Given this list of marker genes PRR4, BCL2, DGKA, CKMT2-AS1, MT1E, SFRP1, CCL20, LINC01133, GNE, BICDL2, TNFAIP8, PTGER4, NCALD, GPR173, CYP4X1, KCNK6, SAYSD1, MGAT2 (alpha-1,6-mannosyl-glycoprotein 2-beta-N-acetylglucosaminyltransferase), FAN1, CBLC, BCL3, SPATA13, ATL3, ZNF554, MESP1, TSPAN1, CLDN10, ABO, CYP4V2, MUC20, SHLD2, COL28A1, SRGAP1, CRYM, NEBL, NTN1, CXCL6, CBR3, SMIM22, ZNF774, ZC3H3, SLC49A3, VTCN1, CBFB, ACSL4 (acyl-CoA synthetase long chain family member 4), SLCO3A1, SLC35F6, NMRK1, CASP4, CRYBB2, SH2D3A, TYMP, TNFSF13B, NRAD1, PKN2-AS1, GAL3ST4, CCDC146, IGFBP3, MYO18A, PFKP, TNFRSF14, FOXRED2, MIR200CHG, MIRLET7BHG, TMEM63A, KCNN4 (potassium calcium-activated channel subfamily N member 4), PRSS21, ELAPOR1, B3GNT5, TRIM47, SOX21, ZNF217, TTYH1, CCDC160, ANKRD9, OAF, ARHGAP27, ATP2A3, NPM2, TTC9, GDPD5, SHC2, NBPF3, C10orf143, MFSD6L, CAPN10, EZH1, GRHL1, LINC00920, SYT7, PHLDA2, CHFR, F8A1, CFH, MEIS1, TUBB6, STXBP5, CAVIN1, NALCN, PITPNM3, HLA-B, CBX4, RRAS, PIM2 (Pim-2 proto-oncogene, serine/threonine kinase), SEZ6L2, DST, EXTL3, SLC1A5, TGM5, TMEM40, KCNMA1, BTBD6, GABRP, PHF7 (NCBI Gene Id 51533), HTRA1, NEURL3, AK4, ZNF701 (zinc finger protein 701), CALML5, CFAP96, SH3PXD2B, SNX19, S100A2, SLC25A25-AS1, GCLM, AJM1, INHBB (inhibin subunit beta B), C8orf58, PRR15, PPP1R3F, TMT1A, EDEM1, CIMAP1B, CEACAM6, ARHGEF3, AEN, PSME4, SLC30A4, CAVIN3, PHLDB3, SOCS6, CHAF1B, SULT1A3, PTPN18, PCDHB16, NOL3, LHFPL2, RAPGEF5, CPEB2, RTTN, ATL1, SULF2, ZBTB7C, FAM83E (NCBI Gene Id 54854), PLLP, PPP5D1P, LZTS3, MARCHF3, SLC66A2, GALNT6, ARRDC4, EFHD1, SDCBP2-AS1, GRAMD2B, MIF4GD, FAM83A, IDH1-AS1, MICALL2, SPDEF, PYGL, TCN1, REPS2, TSPAN5, ITFG2-AS1, TENT5A, GHR, ANG, NPB, COMTD1, RASAL1, DHRS12, RGS10, NOP14-AS1, GLIS3 (NCBI Gene Id 648268), NPNT, BARX2, HS3ST1, TFAP2C, LNX1, ITGB8, IL17RC (interleukin 17 receptor C), C19orf73, LINC01473 (long intergenic non-protein coding RNA 1473), DTX4, AVPI1, C14orf93, MRAS, NECTIN1, CAPS, S100B, UBXN8, KANK4, PRKAR2B, CCT6B (chaperonin containing TCP1 subunit 6B), DNAJC28, LENG9, IQSEC2, TIRAP, FAM3D, METRN, C17orf58, CD40, CDR2, SRF, MMP7, NCK2, KLK10, PLAAT3, THBS3, SPHK1, HSH2D, A1BG, SQOR, TACC2, EMB, SELENOV, KAT2B, FAM229A, CHRM3, BIK, TEX261, STK10, SH3BP4, KRT6B, LYN, CNNM4, EIF4EBP3, RILPL2, ST6GALNAC1, CRLF3, ERCC6L2-AS1, C1orf115, JDP2, STEAP1, DEPTOR, SLC39A8, CLDND2, ALDH1A3, ERAP2, MICALL1, CATSPERG, CCSAP, KRT23, PODXL, PDZK1IP1, ANGPT2, LURAP1L, REEP2 (receptor accessory protein 2), CDKN1A, VEGFC, ASB13, RPS6KA4, GSTA1, TNFAIP2, RHBDL1, FNDC10, NPIPB11, BPGM, HARBI1 (harbinger transposase derived 1), ZNF788P, PALLD, TMEM71, SLPI, IQCH-AS1, CCL28, RNF144B, MCC (MCC regulator of WNT signaling pathway), PHLDA1, PER2 (NCBI Gene Id 8864), ADAD2, EYA2, WNT5B, SLC4A11, TFAP2A, C17orf49, KCTD14, ANO1, SZT2, ARID5A, GXYLT2, SECTM1, RRAGD, SLCO1A2, HAPLN3, FOXQ1, NMNAT3 (NCBI Gene Id 349565), TMEM241, PITPNC1, GALNT12, TNFSF10, C2CD4D, KRT14, FRMD6, CRIM1, RAB27B, KIF16B, CP, SLC22A23 (solute carrier family 22 member 23), NUPR1, TAPBPL, KLK11, SLITRK6, MARCHF2, SMPDL3A, PDE12, MGP, BAK1 (NCBI Gene Id 578), CLCF1, PLA2G6, MAP1B, IGFBP4, RIPOR2, RDH13, SLC5A1, RRP36, ANPEP, KHDRBS3, BCDIN3D, TPBG, CD14, A2M, BLM, VSIR, LGR4, ZNF449, PACS1, WFIKKN1, LRIG1, PPM1H, SELENOM, CDCP1, OPLAH (NCBI Gene Id 55579), HDHD5-AS1, FRZB, NPDC1, PNPLA7, CD3E, GMPR, SLC33A1, SGPP2, CFD, PINK1, GGT6, MZF1-AS1, DAGLB, TSHZ2, SYCE1L, GNG7, BCAR3, PXDC1, GLIPR2, CITED4, NEURL4, PALMD, F3, PRKCH, SYTL3, PPP1R1B, ADAM28, FOSL1, CRYAB (crystallin alpha B), TRIM17, MLYCD, ANKRD35, SLC37A1, NTRK2, CLPB, ABHD17B, RHOV, GATM, USP43, SLC44A4, PCSK6, PSMG3-AS1, PROM1, TOX3, MHENCR, ZNF212, NUMBL, CRACR2A, AQP5-AS1, ESYT2, ADM2, PITPNA, TNFSF12, BAIAP3, AZGP1, ACP5, TSPAN8, H2AC15, EHF, RBP7, MOB3C (NCBI Gene Id 148932), RORA, SCGB1A1, PPFIA3, MLPH, COL6A2, RCAN1, PPT2, PTPRE, TMC5, PPFIBP2, NQO1, GABBR1, CSTA (NCBI Gene Id 378889), FABP7, WHRN, KRT15, CNFN, INHBA, TENT5B, SLCO4C1, PEX11G, CYTH3, LTC4S, MIATNB, ABHD17C, TMEM139, RNF152, TMCO4, DENND5A, SPSB2, ZNF70 (zinc finger protein 70), DHRS4L2, ABCB10, ARHGDIB, CIMAP1C, SH3BP5, CCNO (NCBI Gene Id 9998), FBXO32, COG8, ABCA3 (NCBI Gene Id 21), HHAT, NPHP3, ADIPOR2, LTF, PIP, ARHGEF37, SLIT3, ADGRG1, ARHGAP31-AS1, PIK3CD-AS2 (NCBI Gene Id 101929074), FBXL8, PIK3IP1, RETSAT, MMAA, SOX21-AS1, IKBKE, ZDHHC2, ZFPM1, LINC00847, KLF11, RUNX1 (NCBI Gene Id 861), GNA15, HIVEP3 (HIVEP zinc finger 3), BBS5, CDC42EP2, TSLP, THSD4, PART1, ARSJ, ANXA1, MAFB, FMOD, BORCS6, B3GNT3, NPEPL1, RBM27, POU2F3, NACAD, ENDOG, MFSD6, FOLH1, APOBEC3C, AREL1, SH3RF1, DOCK9, ZNF296, NSMF, NBL1, LRRC26 (leucine rich repeat containing 26), ISL1, LINC00992, RNF150, LYPD3, ST3GAL4, PADI2, MEG3, PROSER2, PDK3, BMAL1, WNK2, STEAP2, WIPI1, IQCH, AQP5, FUT2, TRPS1, FGD5, SOX10 (NCBI Gene Id 8223), TIMP1, ORAI1, IFI16, RUNX3, PTH2R, TAP2, TGM2, CXCL3, RTN4IP1, ZSWIM8, SLC2A9, PKP2, EVA1C, HEY2, ZNF598, KAZALD1, STPG1, PDE4B, PTRH1, SFN, MYO15B, PMEPA1, CLYBL, ITGB4, CD82, GFM1, SMIM31, PLPP2, ZNF750, SLC25A10, SLC43A3, GLYATL2, GK, PLAAT4, PHF8, MKRN2OS, GRTP1, SERTAD4, NIPAL2, AGFG2, SLC5A8, ATG2A, ST20, RIC3, LINC01644, ST3GAL1, LINC01198 (NCBI Gene Id 101929344), LRATD1, ARHGEF11, DTX2, ELMO1, ABHD15, MUC5B, SLC25A42, SERTAD4-AS1, CNTN4, WAC-AS1, SUSD6, ANKRD13C-DT, KRT86, DUSP4 (dual specificity phosphatase 4), CRPPA, TCEA3, TM4SF1, IQGAP2, TIGD2, RASSF6 (Ras association domain family member 6), DCUN1D1, C9orf152, TNFSF13 (TNF superfamily member 13), RENBP, KLF9, VCAN, NOXO1, RASSF5, FBXO6, ZNF30, SLC15A2, EPS8L1, PAX9, EML5, ZNF426-DT, LMBRD2, CSK, ZNF524, PDLIM2, ETV4, CXCL8, TF, LARS2, ENTPD2, MR1, WFDC1, CLGN, STARD5, NIPAL1, ZHX3, PTPN23, FAM83H, TMEM238, COBL, FHL2, CXCL2, LINC01876, CHRNA7, LGALS9, CASC8, CLDN8, ISG20, SIX1, CLMN, CASZ1, MANSC1, PAX1, KRT4, CHST9, SPIRE2, RINL, SLC25A21 (NCBI Gene Id 89874), CHRM1, ITPRIPL1, CEP120, SLC35A3, UACA, NR4A2, NRBP2, ZNF319, CYP2F1, RAB3D, SULT2B1, ATP12A, MT3, CYB5R2, GHDC, SCGB3A1, TMCO3, ATP6V1E2, ARHGEF38 (NCBI Gene Id 54848), N4BP3, SLC9A1 (solute carrier family 9 member A1), KRT7, BHLHE40, FBXO27, PCAT6, CNGA1, SYBU, ITPR2, SLC4A3, LINC02188, CFB, PDF, LINC00342, SBNO2, GPR137B, HEY1, KIF13B, SLC25A43, LRRC1, CD83, MYC, FGGY, MUC16, SLC25A27, PITX1, RDH10, DEAF1, GBA1, ZNF12, IQCE, RTN2, ARHGEF35, POLR2J3, SLC9A6, CALCRL, INSR, CARD6 (caspase recruitment domain family member 6), FGFRL1 (fibroblast growth factor receptor like 1), DGKH (diacylglycerol kinase eta), FXYD5, KIAA1671, RNF227, ZG16B, VEGFB, PLPPR2, GBP1, LPAR6, FKBP11, AEBP1 (NCBI Gene Id 165), CA8, FCGBP, OPTN, CBS, ZNF513, PF4V1, CCDC163, UNC5CL, FOXC1, FMO5, LINC00649, HSD17B2, LCN2, DEFB1, SNAPC4, LINC01535, FRMD4A, SLC45A4 (solute carrier family 45 member 4), PRAP1, RGCC, DSC2, PKP1, SOSTDC1, ZBTB8A, FAT2, FRAT2, SLC43A2, TRIM29 (tripartite motif containing 29), HSD3B7, AGAP5, LPGAT1, GK5, ITPKC, LPCAT2, RETREG1, TGFA, FBLN2, LSP1, CAB39L, ZNF182, CXCL1, FOXO1, FCMR (NCBI Gene Id 9214), EPHX4, IFNAR2, AREG, AACS, OGFRL1, CX3CL1, UTP20, ASS1, LIPE-AS1, CDC42BPG, SAMHD1, TMEM131L, SOX8, NEIL1, SIX2, PLA2R1, BEND7, RBM14, NR2F2-AS1, BOK, TM4SF1-AS1, DENND1A, C4orf19, SEC24A, FYCO1, NFATC1, TRAK1, SLC66A3, ZNF385C, RIN2 (Ras and Rab interactor 2), LINC01023, MIA, here is a description of the gene set: studied in species Homo sapiens SMG Human Gene Set: HE_LIM_SUN_FETAL_LUNG_C1_SMG_CELL from publication He P, Lim K, Sun D, Pett JP, Jeng Q, Polanski K, Dong Z, Bolt L, Richardson L, Mamanova L, Dabrowska M, Wilbrey-Clark A, Madissoon E, Tuong ZK, Dann E, Suo C, Goh I, Yoshida M, Nikolić MZ, Janes SM, He X, Barker RA, Teichmann SA, Marioni JC, Meyer KB, Rawlins EL (PMID 36493756)